The following is a description of a gene set: Binds to and stops, prevents or reduces the activity of a lipase, an enzyme that catalyzes of the hydrolysis of a lipid. studied in species Homo sapiens Human Gene Set: GOMF_LIPASE_INHIBITOR_ACTIVITY, and this is the list of marker genes: APOA2, ANXA1 (annexin A1), ANGPTL4, APOC3, ANXA5, ANXA8, ANXA4, APOC1, SNCA, FAF2, PINLYP, APOC2 (apolipoprotein C2), PLA2R1 (phospholipase A2 receptor 1), ANGPTL3, SNCB, PDC, SCGB1A1, ANXA2, ANXA3, ANXA2P2